The following is a description of a gene set: Human Gene Set: GOBP_AMINO_ACID_BETAINE_TRANSPORT studied in species Homo sapiens The directed movement of betaine, the N-trimethyl derivative of an amino acid, into, out of or within a cell, or between cells, by means of some agent such as a transporter or pore., and this is the list of marker genes: SLC6A14, SLC25A20, SLC25A29, SLC6A12, SLC22A1, SLC7A6, SLC16A9, SLC22A15, SLC38A2, SLC6A20, SLC22A4, PDZK1, SLC22A16, SLC22A5 (solute carrier family 22 member 5)